The following is a description of a gene set: species: Mus musculus Mouse Gene Set: GOBP_VIRION_ASSEMBLY A late phase of the viral life cycle during which all the components necessary for the formation of a mature virion collect at a particular site in the cell and the basic structure of the virus particle is formed., and this is the list of marker genes: Vps37b, Chmp4b, Chmp5, Chmp4c, Chmp3, Chmp1b2, Apoe, Chmp2a, Rab1b, Spcs1, Vps4b, Chmp2b, Nedd4, Lrsam1, Chmp1a, Rab1a, Tbc1d20, Ddx6, Mvb12a, Mvb12b, Pcx, Chmp6, Pdcd6ip, Chmp1b, Usp6nl, Tsg101, Chmp7, Vps4a, Rab43